Given this list of marker genes Vamp2, Vapa, Sec61b (SEC61 translocon subunit beta), Sec61g (SEC61 translocon subunit gamma), Emd, Serp1, Stx1a, here is a description of the gene set: part of: Protein localization electronically inferred by orthology from the curated human pathway Reactome Pathway: Insertion of tail-anchored proteins into the endoplasmic reticulum membrane species: Mus musculus This event has been computationally inferred from an event that has been demonstrated in another species.<p>The inference is based on the homology mapping from PANTHER. Briefly, reactions for which all involved PhysicalEntities (in input, output and catalyst) have a mapped orthologue/paralogue (for complexes at least 75% of components must have a mapping) are inferred to the other species.